The following is a description of a gene set: Mouse Gene Set: GOBP_NEGATIVE_REGULATION_OF_MHC_CLASS_II_BIOSYNTHETIC_PROCESS studied in species Mus musculus Any process that stops, prevents, or reduces the frequency, rate or extent of the chemical reactions and pathways resulting in the formation of MHC class II., and this is the list of marker genes: Nfx1 (nuclear transcription factor, X-box binding 1), Taf7, Il10, Spi1, Marchf8